The following is a description of a gene set: Human Gene Set: GOBP_REGULATION_OF_SMOOTH_MUSCLE_CONTRACTION studied in species Homo sapiens Any process that modulates the frequency, rate or extent of smooth muscle contraction., and this is the list of marker genes: MIR145, F2R, CAV1, GHRL, TACR3, ZDHHC21, KCNB2, NMU, RGS2, RHOA, CNN1, TBXA2R, NPY2R, STUB1, ADA, EDN2 (endothelin 2), PRKG1, ITGA2, OXT, ATP1A2, MYOCD, ADRA2A, GHSR, DAPK3, CHRM2, CHRM3, ABAT, ORMDL3, ADRA1A, MIR143, ADRB2, MIR21, CHRNB4, MIR153-1, SRF, CALCA, TNNI3, NPNT, SPHK1, SOD1, ADORA2B, SPX, ADRA2B, NMUR2, IRAG1, DOCK5, TACR1, MAP2K1, CTTN, EDN3, PROK2, KIT, GUCY1A1, P2RX1, DOCK4, ADRA2C, GPER1 (NCBI Gene Id 2852), CHRNA3, EDN1, SETD3, ATP2B1, ARHGAP42, TACR2